Given this list of marker genes PLCG1, EFNA2, NGEF, FYN, EPHA6, EPHA2, EFNA5, EPHA7, CRK, BLK, RHOA, PIK3CG, VAV3, EPHA8, EPHA4, EFNA3, SRC (NCBI Gene Id 6714), CBL, LYN, FGR, EPHA3, YES1, EPHA5, EPHA1, PIK3R6, ARHGEF15, PIK3R5, CRKL, VAV2, LCK, CDK5, HCK, ROCK1 (Rho associated coiled-coil containing protein kinase 1), EFNA1, here is a description of the gene set: from publication Schaefer CF, Anthony K, Krupa S, Buchoff J, Day M, Hannay T, Buetow KH (PMID 18832364) EPHA forward signaling Human Gene Set: PID_EPHA_FWDPATHWAY studied in species Homo sapiens